Given this list of marker genes Atp2b4, Eng, Cav3, Gla (NCBI Gene Id 11605), Nosip, Cav1, here is a description of the gene set: species: Mus musculus Any process that stops or reduces the activity of the enzyme nitric-oxide synthase. Mouse Gene Set: GOBP_NEGATIVE_REGULATION_OF_NITRIC_OXIDE_SYNTHASE_ACTIVITY